The following is a description of a gene set: Human Gene Set: GSE39820_CTRL_VS_IL1B_IL6_IL23A_CD4_TCELL_DN TGF-beta3 produced by developing Th17 cells induces highly pathogenic T cells that are functionally and molecularly distinct from TGF-beta1-induced Th17 cells. The microarray data represent a distinct molecular signature for pathogenic versus non-pathogenic Th17 cells. species: Homo sapiens from publication Lee Y, Awasthi A, Yosef N, Quintana FJ, Xiao S, Peters A, Wu C, Kleinewietfeld M, Kunder S, Hafler DA, Sobel RA, Regev A, Kuchroo VK (PMID 22961052) Genes down-regulated in comparison of untreated CD4 T cells versus those treated with IL1B, IL6 and IL23A., and this is the list of marker genes: MCTP2, RNF149, DLG2, KLHL6, DDIT3, NFKBIZ, GPR171, CDS2, GCH1, SH3GLB1, INTS12, YPEL3, MALT1, CST7, ITGA3, BCL2L15, BEND4, SIRT7, THEMIS, CRELD2, GALC, MARCHF7, CRCP, CD28, ALDH3A2, MED30, TSPAN6 (NCBI Gene Id 7105), STARD5, GEM, RFC3, PLEK, CYSLTR1, RAB11FIP1 (RAB11 family interacting protein 1), YPEL5, GOLGA7, RHOQ, SPESP1, PAIP2, RAPGEF5, SOX5, CYFIP2, SH3RF1, DRAM2, PDIA6, SKAP2 (src kinase associated phosphoprotein 2), UPP1, PARP16, CSNK1G3, CASP6, PPM1J, FRMD4B, SCCPDH, RAB26, RAB1A, CST9L, SMOX, PLCD4, TMEM43, EHD4, NDRG1, TWSG1, GZMA, PTPRK, GSTM5, ETV6, SDF4, DDR1, GJA1, CARHSP1 (calcium regulated heat stable protein 1), FAU, STX7, STOM, DLEU7, EHBP1L1, SERPINE1, LIME1, ENPP2, GPR18, PLAC8, PPP1R3B, EBF1, AIMP1, CAST, C1orf21, PAQR8, MFHAS1, TOX2, TIMP1, SYPL1, SEMA4F, MDM2, NFE2L2, NDST1, HS1BP3, SERTAD1, IGKC, APPL2, BCL3, TNFSF14, DACH2, TNIP1, CMAS, CRBN, USP3, TRPM4 (NCBI Gene Id 8184), DUSP22, CA13, ECM1, POLD4, SNAPC1, MED12L, PTGR3, EIF2B2, PRKCH, FNDC3A, SUPT3H, GATM, PRRC1, CD200, FOSL2, ANXA2, CHD7, ZBTB21, INHBA, LAMC1, VIM (vimentin), MT2A, SLC4A11 (NCBI Gene Id 9574), IL17A, RNH1, LUM (NCBI Gene Id 4060), SPECC1, SLAMF1, PIWIL2, CHM, AREL1, CRTAM, ITM2C, CCDC63, GSTT1, PHF7, SEC61G, CCNI, KIAA1958, ID2, PSTPIP1, MED10, MANF, TRAF1, MAP2K6, ARMCX3, ARHGEF10, FTH1, SLC35B1, CDKN2D, RANBP9 (NCBI Gene Id 10048), DCTN4, SELENOS, MYO10, OCIAD2, ZC3H12D (NCBI Gene Id 387078), IRAK2, SMIM3, NUCB2, PDGFA, NSF, LPXN, MGLL, VILL, TBCEL, CELA1 (chymotrypsin like elastase 1), COX7A1 (cytochrome c oxidase subunit 7A1, NCBI Gene Id 1346), CPD, GMFG, GOLGB1, RIOX2, RND1, SUSD3, NOP53, ALCAM, UBE3D, HVCN1, SLC39A14, AMZ2, CREB3L2, ARAP1 (NCBI Gene Id 23290), SGIP1, TMEM218, NATD1 (N-acetyltransferase domain containing 1), S100A6, PFKFB4, IL21, SRGN, BNIP3L (BCL2 interacting protein 3 like), ATF6, NEK6, DGAT1, FLOT1, GADD45G, CPVL